Given this list of marker genes St6gal1, Srebf1, Dbnl, Mgat4c (MGAT4 family, member C), Ndst1, Fut11, Ftcd, Cog7 (NCBI Gene Id 233824), Steap4, Llgl1, Rab29, Zdhhc14, Golga4, H2-Q6, Chst10, Slc35a3, Pomgnt1, Uso1, Golga3, A4galt, Ldlrad4, Zdhhc20, Slc16a13, Xylt1, Grina, Rab6b, Vps45, Rheb, Fam20b, Rab11a, Man1a2, Rnd3, Atf6, Mgat1, Lman1, Zdhhc22, Gbgt1, Ebag9, Sec22b, Hid1, Mtor, Il17rd, Rab11fip5, Aph1b, Cope, Casd1, Litaf, Stx16, Copg1, Cog5, Rab12, Has2, Ier3ip1, Apoo, Gabarap, Qsox2, Hyal2, Gbp5, Ap1g2, Man2a1, H2-Q1, Arfgef2, Dennd5a, Drd2, Faim2, Galnt17, Psen1, Zdhhc8, Tpst1, Panx2, Notch1, Arcn1, Asap1, Atg9a, Rab9, Sybu, Lyset, Smpd4, H2-M2 (histocompatibility 2, M region locus 2), H2-Q10, Cnih1, Pikfyve, Plce1, Plpp3, Galnt14, AU040320, B4galnt1, Ust, Clstn1, Copa, Mymk, Agtrap, Tvp23b, Hepacam2, Tmem59l, Atp8a2, Pmepa1, Gcc1, Rab11fip3, H2-M10.2, Large2, H2-M10.1, Has3, Mfng, Snap29, H2-M11, Sgms1, Cbfa2t3, Kdelr2, Huwe1 (HECT, UBA and WWE domain containing 1), Tvp23a, Mbtps1, Rer1, Zdhhc3, Leprot, Pi4k2b, St6galnac2, St6galnac1, Fktn, Zdhhc12, Abca5, Mospd1, Napepld, H2-Q2, Man1c1, Scara3, Chst7, Hs2st1, Dop1b, Gba2, Zdhhc18 (NCBI Gene Id 503610), St8sia4, Irgm1, Pla2g4a, Bet1l, Abcb4, Syndig1, Rab26, Mpp4, Cracr2a, B3gat2, St8sia1, Hs3st3a1, Creb3l4, Zdhhc19, Cog2, Cog8, Gcnt3, Scap, Clcn5, Maneal, Manea, Nucb1, Slc35b1, Sec16b, Svip, St6galnac4, Cog1, Creb3, B3galt4, Ap3d1, Gosr1, Arl3, Steap2, Rxylt1, Rasgrp1, Slc35a4, St8sia6, Psenen, Lrrk2, Nmnat2, Gbp4, Srebf2, Camk1g, BC004004, Hs3st5, Acbd3, Slc30a10, B3gnt9, Slc35a1, Faah, Mtcl2, Fzd5, Abcb6, Ubiad1, Tbc1d20, Arf1, Hs3st2, Chst2, Galnt11, Galnt13, Chp1, Paqr3, Slc39a13, Galnt12, Sptbn2, Chst11, Igf2r (NCBI Gene Id 16004), Ergic3, Stk26, Adam10, Ext1, Chst15, Slc30a8, Lpcat1, Gnai3, Cog4, Lpcat2, B3gnt4, Tnks2, Tmf1, Kdelr1, Tnfrsf1a, Osbp, Slc9a8, Rhbdd2, Unc50 (unc-50 homolog), Gal3st1, Pld3, Atp2c2, Gosr2, Creb3l2, B3gat3, Ndfip1, Creb3l1, Xylt2, Gpsm1, Lman1l, Tmed10, Slc30a1, B3galt5, Dipk2a, H2-M5, Sh3glb1, Shh, Kdelr3, Dnm1l, Paqr4, Rtn3, Inpp5e, Acer3, Blzf1, Copz1, Tmbim4, Abca6, Rras2, Stx6, Myo18a, Scamp3, Rab33b, Sgms2, Sys1, Zdhhc17, B3gnt8, Chpt1, Nras, Rab21 (RAB21, member RAS oncogene family), Prkn, Map4k2, Ykt6, Golim4, Mymx, Tmem59, Pdcd10, H2-M10.4, Marchf2, Gbp2b, B4galnt2, Emp2, Man2a2, Gper1, Slc35c1, Chst1, Glce, Stx18, Ica1, Yif1a, Bcap31, Pycard, Pcsk4, Coro7, Yif1b, Gnptg, Rhbdf1, Mall, Sec16a, St8sia5, Zdhhc2, Copg2, Arfgef1, St6galnac5, Irgm2, St6galnac6, Mal, Mmgt2, Pi4k2a, Gbp3, Gnpnat1, Galnt16, Ugcg, H2-K1, Copb2 (NCBI Gene Id 50797), Rab2a, Tmem50b, Mmp14 (matrix metallopeptidase 14 (membrane-inserted)), Stk25, St6galnac3, Sorl1, Mgat5b, Gpr108 (NCBI Gene Id 98067), Hs3st3b1, Golt1b, Wasl, St8sia2, Parm1, Arl1 (ADP-ribosylation factor-like 1), Nipal1 (NIPA-like domain containing 1), Pgap4, Mgat3, Rgp1, A4gnt, Samd8, Mapkap1, Cop1, Mgat4b, Copb1, Tapbp, Tmem165, Rhou, Slc35a5, Entpd6, Marchf4, Ext2, Arfgap1, Chst5, Fam20c, Eef1ece2, Naa60, Slc35b2, Dnm2, Arhgap32, Scyl3, Dse, B3gnt7, Ihh, Slc35d2, Aph1a (aph1 homolog A, gamma secretase subunit), Galnt5, Pld1, Ndst3, Zdhhc23, Fndc3a, Ncstn, Rock1, Trim23, B4galt4, Galnt10, B3gnt5 (NCBI Gene Id 94072), Lman2l, Arfip1, Slc50a1, Tmco1, Rab2b, Cog6, Zdhhc15, Arf4 (NCBI Gene Id 30916), Mmd2, Chst4, Sting1, Mbtps2, Glipr2, St3gal2, Gopc, Gcnt7, B3galnt2, Cav2, Tpst2, Lfng, Wscd1, Ift27, St3gal6, H2-T22, Zdhhc7, Fut10, Lman2, Arfgap3, Usp32, Entpd4b, Rtn1, Galnt18, Wscd2, Tmem167, Trappc3, Qpctl, St8sia3, Traf3ip3, Gfy, Hras, Gcnt4, Mgat4d, Sec23a, Large1, Nlrp3, Cav1, Whamm, Tmed9, Galnt7, Marchf9, Gcnt2, Sacm1l, Arfgap2, Egfr, Vti1a, Ndst4, Ptges2, Prkce, Qsox1, Pcsk7, Arhgap21, Erc1, Tex261, Hpd (4-hydroxyphenylpyruvic acid dioxygenase), Mapk8ip3, Tnks, Rnf125, Acer2, Wls, Slc30a7 (NCBI Gene Id 99654), Cabp1, Golga5, Gnptab, Chst3, Grm6, Clstn3, Abca7, B4gat1, Pgap2, Rap1gap, Pgap3 (NCBI Gene Id 320655), Pitpnb, Dhh, Mgat5, Yipf6, Cyp2e1, Snapin, Ndst2, Stx12, Mphosph9, B3galt2, Slc10a7, Rab6a, Gad2, Cux1, Galnt4, Atp2c1, Pja2, Atl1, Pi4kb, Asah2, Scfd1, Fkrp, Abcb1b, Golga2, Zdhhc21, Otof, Tmem167b, Pcsk5, Galnt15, H2-Q7, Lmtk3, Ece2, Gbf1 (golgi-specific brefeldin A-resistance factor 1), Hs3st6 (heparan sulfate (glucosamine) 3-O-sulfotransferase 6), Cln3, Scoc, B3galt1, Tmem87a, Gorasp2, Plekhb1, B3gnt6, Chst12, Armh3, Cdc42, B3galt9, Chst9, Mr1, Galnt6, Gabarapl2, Slc35b4, Golph3, Golt1a, Srgn, Pkmyt1, Chst14, H2-D1, B3galnt1, B3gat1, Kif13a, Vapa, Lysmd3, Gbp2, Rab1a, Man1a, Rnf24, Golga7b, Rab14, B3galt6, Bet1, Cfp, Smpd3, Tmem87b, Slc2a1, Glg1, Ergic1, Hhat, Gimap1 (NCBI Gene Id 16205), Zdhhc9, Copz2, Sppl2b, Atg9b, B3gnt2, Gpr89, Marchf8, Rac1, Trappc4, Mmgt1, B3gnt3 (NCBI Gene Id 72297), Dhcr24, Psen2, Golga7, H2-M10.6 (histocompatibility 2, M region locus 10.6), Actr3, Gask1b, Slc35a2, Igtp, Stk24, Tlcd3b, Gcnt1, Zdhhc4 (zinc finger, DHHC domain containing 4), Entpd4, Furin, Tmc8, Abcg1, Abca12, Cspg5, St3gal5 (ST3 beta-galactoside alpha-2,3-sialyltransferase 5), Scamp5, Vps13b, Fut9, Ric1, Rab36, Cav3, Hace1, Serinc3, Zdhhc13, Tapbpl, Tmem132a, Rfng, Spring1, Slc30a5, Surf4, Chst8, Pxylp1, Abcb11, Tmem130, Mgat4a, Mgat2, Rnf121, Slc26a9, Itm2b, Stx5a, Clstn2, Slc35b3, Prkci, Dop1a, here is a description of the gene set: The lipid bilayer surrounding any of the compartments of the Golgi apparatus. species: Mus musculus Mouse Gene Set: GOCC_GOLGI_MEMBRANE